The following is a description of a gene set: species: Mus musculus from publication Iglesias A, Murga M, Laresgoiti U, Skoudy A, Bernales I, Fullaondo A, Moreno B, Lloreta J, Field SJ, Real FX, Zubiaga AM (PMID 15146237) Genes up-regulated in pancreatic cells from mice with double knockout of E2F1 and E2F2 compared to wild type. Mouse Gene Set: IGLESIAS_E2F_TARGETS_UP E2F transcription factors are thought to be key regulators of cell growth control. Here we use mutant mouse strains to investigate the function of E2F1 and E2F2 in vivo. E2F1/E2F2 compound-mutant mice develop nonautoimmune insulin-deficient diabetes and exocrine pancreatic dysfunction characterized by endocrine and exocrine cell dysplasia, a reduction in the number and size of acini and islets, and their replacement by ductal structures and adipose tissue. Mutant pancreatic cells exhibit increased rates of DNA replication but also of apoptosis, resulting in severe pancreatic atrophy. The expression of genes involved in DNA replication and cell cycle control was upregulated in the E2F1/E2F2 compound-mutant pancreas, suggesting that their expression is repressed by E2F1/E2F2 activities and that the inappropriate cell cycle found in the mutant pancreas is likely the result of the deregulated expression of these genes. Interestingly, the expression of ductal cell and adipocyte differentiation marker genes was also upregulated, whereas expression of pancreatic cell marker genes were downregulated. These results suggest that E2F1/E2F2 activity negatively controls growth of mature pancreatic cells and is necessary for the maintenance of differentiated pancreatic phenotypes in the adult., and this is the list of marker genes: C1qc, Cadm1, Smad1, Lcp1, Tank, C3, Enpp2, Col3a1, Nfib, Hspa1l, Lpl, Morf4l1-ps1, Ccnd2, Gbp3, Eln, S100a11, Gnb1 (NCBI Gene Id 99986), Mcm5, Csrp1, Rbbp7, Emp1, Ccng1, Pcna, Cks1b, Fbln2, Col1a1, Itm2a, Nptn, Scg2, Tuba1a, Zfand5, Sparc, Crtap, Adipoq, C1qb, Dcn, Cdc6, Cfd, Sat1, Hnrnpa2b1, Arsa, Cxcl13, Itgb1, C1qa, Smc2, Cd74, Lyz1, Akirin2 (akirin 2), Gja1, Cacybp, Mfap2, Col5a2, Col15a1, Timm22, Septin2, Gsn, Ogn, Laptm5, Ctss, S100a13, Cd9, Pmp22, Slc25a4, Rhob, Anxa3, Serpinf1, Col18a1, Nfkbia, Lama4, Tmem45a, Anxa2, Cdc42, Nid2, Apoe, Lmna, Lims1, Aplp2, Lum, Capza2, Col6a2, Clk1, Acta2 (actin alpha 2, smooth muscle, aorta), Tuba1b, Hba-a1, Gas6 (growth arrest specific 6), Pkd2, Adh5, Krt19, Tubb5, Acadm (acyl-Coenzyme A dehydrogenase, medium chain), Col4a1, Postn, Col6a3, Septin7, Igfbp5, Evl, Mcm7, Acadl, Serpinb6a, Tyrobp, Dab2, Ctsz, Actg1, Cd53, Tubb2a, Calm2, Bzw1, Ces1d, Kitl, Fmo1, Col1a2, Bax, Gnai2, Igfbp4, Lgals1, Rbp1, Lyl1, Cdkn1c, Mcm3, Car3, Dstn, B2m (NCBI Gene Id 12010), Ccl9, Cnn3, Ugdh, Cd47, Laptm4a (NCBI Gene Id 17775), Angptl2, Crip1, Alas2, S100a6, Eed, Ap4s1, Ctse, Cdo1, Ss18, Serpinh1, Itm2b, S100a10, Cd34, Cyfip1, Agr2, Mrc1, Dnaja1, Skp1